The following is a description of a gene set: The transfer of electrons from cytochrome c to oxygen that occurs during oxidative phosphorylation, mediated by the multisubunit enzyme known as complex IV. Human Gene Set: GOBP_MITOCHONDRIAL_ELECTRON_TRANSPORT_CYTOCHROME_C_TO_OXYGEN species: Homo sapiens, and this is the list of marker genes: COX7C, MT-CO3, MT-CO2, COX6A1, CYCS, COX7B, COX5A, COX5B (NCBI Gene Id 1329), COX7A2, COX4I1 (NCBI Gene Id 1327), MTCO2P12, COX6B1, COX6A2 (cytochrome c oxidase subunit 6A2), COX7A2L (NCBI Gene Id 9167), NDUFA4, COX7A1, COX6C, COX4I2, COX7B2, COX8A, COX7A2P2, COX8C, MT-CO1